The following is a description of a gene set: species: Homo sapiens Human Gene Set: HP_ANTERIOR_CHAMBER_SYNECHIAE Anterior chamber synechiae, and this is the list of marker genes: CYP1B1, PTPN22, IL2RB, OVOL2, LARGE1, LCA5, CD247, IL2RA, ADAMTS17, PTPN2, ZEB1, FOXC1, SPATA7, B3GLCT, ASPH, LRAT, NDP, PXDN, MIR204, COL8A2, GRHL2, STAT4, FAS, RPE65 (retinoid isomerohydrolase RPE65), PAX6, COL18A1, ATOH7, ANKRD55, VSX1, PITX2 (paired like homeodomain 2), HMX1, FOXE3